The following is a description of a gene set: Catalysis of the reaction: S-adenosyl-L-methionine + rRNA = S-adenosyl-L-homocysteine + rRNA containing methylcytosine. species: Homo sapiens Human Gene Set: GOMF_RRNA_CYTOSINE_METHYLTRANSFERASE_ACTIVITY, and this is the list of marker genes: METTL15P1 (methyltransferase like 15 pseudogene 1), NSUN5, METTL15, NOP2, NSUN4